Given this list of marker genes Thtpa, Gsto1, Slc19a2, Pdxk, Pnpo, Rgn, Slc25a19, Gulo, Slc19a3, Ugt1a6a, Akr1b1, Akr1a1, Rfk, Tpk1, here is a description of the gene set: The chemical reactions and pathways resulting in the formation of any of a diverse group of vitamins that are soluble in water. Mouse Gene Set: GOBP_WATER_SOLUBLE_VITAMIN_BIOSYNTHETIC_PROCESS studied in species Mus musculus